The following is a description of a gene set: DNAJB1-PRKACA fusion in fibrolamellar liver cancer Human Gene Set: WP_DNAJB1PRKACA_FUSION_IN_FIBROLAMELLAR_LIVER_CANCER studied in species Homo sapiens, and this is the list of marker genes: HDAC7, PRKACA, SIK2 (salt inducible kinase 2), SIK3, CREB1, SIK1, HDAC5, HDAC4, GNAS, DNAJB1, CRTC2 (CREB regulated transcription coactivator 2)